The following is a description of a gene set: Rhizomelic arm shortening Disproportionate shortening of the proximal segment of the arm (i.e. the humerus). Human Gene Set: HP_RHIZOMELIC_ARM_SHORTENING species: Homo sapiens, and this is the list of marker genes: FZD2, COL2A1, DYM, FGFR2, SHOX, KIAA0586, CSPP1, GPX4, SLC26A2, MYSM1